The following is a description of a gene set: Reactome Pathway: Defective F8 secretion Hemophilia A (HA) is a bleeding disorder caused by lack of or a defective factor VIII (FVIII) protein and results from defects in the F8 gene (Peyvandi F et al. 2016).<p>In healthy individuals, FVIII is synthesized as a large glycoprotein of 2351 amino acids with a discrete domain structure: A1-A2-B-A3-C1-C2 (Wood WI et al. 1984; Vehar GA et al. 1984; Toole JJ et al. 1984). Upon synthesis, FVIII is translocated into the lumen of the endoplasmic reticulum (ER), where it undergoes extensive processing including cleavage of a signal peptide and N-linked glycosylation at asparagine residues (Kaufman RJ et al. 1988, 1997; Kaufman RJ 1998). In the ER lumen of mammalian cells FVIII interacts with the protein chaperones calnexin (CNX), calreticulin (CRT), and immunoglobulin-binding protein (BiP or GRP78) that facilitate proper folding of proteins prior to trafficking to the Golgi compartment (Marquette KA et al. 1995; Swaroop M et al. 1997; Pipe SW et al. 1998; Kaufman RJ et al. 1997; Kaufman RJ 1998). Trafficking from the ER to the Golgi compartment is facilitated by LMAN1 and multiple combined factor deficiency 2 (MCFD2) cargo receptor complex (Zhang B et al. 2005; Zheng, C et al. 2010, 2013). Within the Golgi apparatus, FVIII is subject to further processing, including modification of the N-linked oligosaccharides to complex-type structures, O-linked glycosylation, and sulfation of specific Tyr-residues (Kaufman RJ 1998). Upon secretion from the cell, FVIII is cleaved at two sites in the B-domain to form a heterodimer consisting of the heavy chain containing the A1-A2-B domains in a metal ion-dependent complex with the light chain consisting of the A3-C1-C2 domains (Kaufman RJ et al. The module includes also an event of defective post-translational tyrosine sulfonation of FVIII in the Golgi apparatus that is required for the optimal interaction between the secreted FVIII and the von Willebrand factor (VWF). part of: Defective factor VIII causes hemophilia A species: Homo sapiens, and this is the list of marker genes: F8